Given this list of marker genes BTBD8, ACTB, SYT7, CLTA, OPHN1, TBC1D24, AMPH, WNT3A, CAPN2, ITSN2, RAB3A, SGIP1, PLAA, SCRIB, FCHO2, SYNJ2, CANX, AP2B1, DNM3, SNCG, PPP3CC, STX1B, PPP3CB, AP3S1, NLGN1, DNM2, SLC17A7, AP2M1, SH3GL2, PIK3C3, TOR1A, SYT11, MX2, VAMP4, ACTG1, AP3D1, NLGN3, CTBP1, MYLK, MX1, GAK, PLD2 (phospholipase D2), VAMP2, BLTP1, ARF6, PRKN, SLC2A4, CLTB, BTBD9, ARPC3, LRRK2, ROCK1, DNAJC6, STON2, CALM3, PARK7, GRIPAP1, AP3M2, AP2A2, DNM1, SNX9, GIT2, RAB7A, DGKQ, PIP5K1C, RAB27B, AP3S2, RAC1, ATP8A1, SYNJ1, STON1, AP2A1, EPS15L1, STX1A, ITSN1, ABCA13, CDK5, SNCB, RAB5A, AP3B2, BIN1, WNT7A, AP2S1, SNCA, AP1G1, GIT1, PACSIN1, here is a description of the gene set: Human Gene Set: GOBP_SYNAPTIC_VESICLE_RECYCLING The trafficking of synaptic vesicles from the pre-synaptic membrane so the vesicle can dock and prime for another round of exocytosis and neurotransmitter release. Recycling occurs after synaptic vesicle exocytosis, and is necessary to replenish presynaptic vesicle pools, sustain transmitter release and preserve the structural integrity of the presynaptic membrane. Recycling can occur following transient fusion with the presynaptic membrane (kiss and run), or via endocytosis of presynaptic membrane. studied in species Homo sapiens